Given this list of marker genes GPN1, KIF5C, RARS2, ZNF532, LY9 (lymphocyte antigen 9), IL1B, WDR20, TMED10, MED27 (NCBI Gene Id 9442), KAT2A, CMIP, CD52, GP9, NEU1, DCK, SF3B5, CRABP2, HLX, GPD2, BMPR1B, PRSS8, NAPSA, TMEM176A, AHI1, APOE, KLRG1, TUBB6, HLA-E, OLR1, CXCL13, CLIC4, KLF10, PLAC8, LY6E, IGF2BP2, RDH5, PREB, ZNF146, ZC3H12C, COL5A2, CCN2, CMTM8, CTSS, BGN, SYNE4, FOXN2, RRM2, LGALS3BP, ZFAND5, BSN, RHD, CSTF2, STXBP3, ALG2 (NCBI Gene Id 85365), FGL2 (NCBI Gene Id 10875), PGK2, SARAF, IFI35, PDCD1, DKK3, IMPA1, CD72, NR4A1, ITGAE, C19orf73, ENG, PLTP, TBP, RBM15 (NCBI Gene Id 64783), TSSK1B, PTGES2, PRKAR1A, RCAN1 (regulator of calcineurin 1), AAAS, ST8SIA3, RPIA, DPM1, NOCT, H1-0, TBX6, PJA1, IL1RL1, MYF6, FLNB, COPRS, SRPRB, FBLN2, MLH1, IGFBP2, TUBB2A, PDK3 (pyruvate dehydrogenase kinase 3), HELLS, FXYD5, TOP3A, POU1F1, TXNRD1, CNN3, TFAP2A, B4GALT6, SLC7A8, PDGFB, TAP1, AIF1, YBX3, AGFG1, SERPINE2 (serpin family E member 2), PLAC9, PXK, CP, SULT4A1 (NCBI Gene Id 25830), SOD2, APOC2, MYO1C, CYTIP, SLC35D1, DBNL, COL1A2, SEMA4D, COL4A2, ANP32A, FRMD6, VNN2, AGL, CSF3R, KMT2A, RING1, DCN, NHP2, ZRANB1, COL18A1, FRRS1, PTPN5, PSMA7, NDUFS6, ELAVL4, SLC23A3, PLK4, MYO1E, ITGA8, GTPBP1, NNMT, NADK, YES1, CCR5 (C-C motif chemokine receptor 5), FKBP10, S100A11, RELB, GLRX, IFIT3, RTN4, TAGLN2, TARS2, TAL1, FJX1, NMB, IL10 (NCBI Gene Id 3586), TMEM183A, HGSNAT, CD47, UBE2L3, GTPBP4 (NCBI Gene Id 23560), SLC3A1, PLS3, CHST2, ANXA1, CXCL14, SLC39A6, TSPAN13, FOLR2, VPS26A, CDKN1C, SBF2, FN1, APBB2, SLC6A18, GJA1, RGL2, MORC4, LY86, LYN, TIMP3, USP18, OR2C1, CYFIP1, AZGP1, UNC5C, GATM, MRM3, ZFPM1, LTBP2, SIX1, ACTN4, CR2, NECAP1, IRF7, SNHG6 (NCBI Gene Id 641638), ACVR2B (activin A receptor type 2B), NCF4, CD5L, H19, here is a description of the gene set: Human Gene Set: GSE43955_1H_VS_10H_ACT_CD4_TCELL_WITH_TGFB_IL6_DN studied in species Homo sapiens Genes down-regulated in CD4 T helper cells Th17 treated with TGFB1 and IL6: 1h versus 10h. Despite their enormous importance, the molecular circuits that control the differentiation of Th17 cells remain largely unknown. Recent studies have reconstructed regulatory networks in mammalian cells, but have focused on short-term responses and relied on perturbation approaches that cannot be applied to primary T cells. Here, we develop a systematic strategy – combining transcriptional profiling at high temporal resolution, novel computational algorithms, and innovative nanowire-based tools for performing gene perturbations in primary T cells – to derive and experimentally validate a temporal model of the dynamic regulatory network that controls Th17 differentiation. The network is arranged into two self-reinforcing and mutually antagonistic modules that either suppress or promote Th17 differentiation. The two modules contain 12 novel regulators with no previous implication in Th17 differentiation, which may be essential to maintain the appropriate balance of Th17 and other CD4+ T cell subsets. Overall, our study identifies and validates 39 regulatory factors that are embedded within a comprehensive temporal network and identifies novel drug targets and organizational principles for the differentiation of Th17 cells. from publication Yosef N, Shalek AK, Gaublomme JT, Jin H, Lee Y, Awasthi A, Wu C, Karwacz K, Xiao S, Jorgolli M, Gennert D, Satija R, Shakya A, Lu DY, Trombetta JJ, Pillai MR, Ratcliffe PJ, Coleman ML, Bix M, Tantin D, Park H, Kuchroo VK, Regev A (PMID 23467089)